The following is a description of a gene set: studied in species Homo sapiens Human Gene Set: HP_ABNORMAL_VESTIBULO_OCULAR_REFLEX An abnormality of the vestibulo-ocular reflex (VOR). The VOR attempts to keep the image stable on the retina. Ideally passive or active head movements in one direction are compensated for by eye movements of equal magnitude. Abnormal vestibulo-ocular reflex, and this is the list of marker genes: CLIC5, KARS1, FXN, RFC1, CACNA1A, FGF14, ESPN, RNF170